Given this list of marker genes Hopx, B4galnt2, Mymk, Gjd4, Klf5, Snhg15 (small nucleolar RNA host gene 15), Cd9, Dysf, Wnt10b, Tarbp2, Kpna1, Plau, Bin3, Igf1, P2rx5, Myf6, Mtpn, Synb, Ppard, Pkm, Large1, Akirin1, Sgca, Mir682, Tmem182 (NCBI Gene Id 98329), Sox15, Anxa1, Wnt7a, Mymx, Bcl9, Hdgfl2, Spaar, Ezh2, Mcub, Gpx1, Mir489, Dmd, Gm34220 (predicted gene, 34220), Dicer1, Cflar, Gja1, Col6a1, Mir675, Ptgfrn, Capn3, Fzd7, Xirp1, Fkrp, Myod1, Pax7, Ifrd1, Myoz1, Dag1, Cd81, Selenon, Mstn, Nfix, here is a description of the gene set: The regrowth of skeletal muscle tissue to repair injured or damaged muscle fibers in the postnatal stage. species: Mus musculus Mouse Gene Set: GOBP_SKELETAL_MUSCLE_TISSUE_REGENERATION